The following is a description of a gene set: Cholecystitis Human Gene Set: HP_CHOLECYSTITIS The presence of inflammatory changes in the gallbladder. species: Homo sapiens, and this is the list of marker genes: F5, ATP8B1, HK1, IGHG2, TPI1, PKLR, POT1, TFE3, ABCB4, GPI, IGKC, ARSA, ALDOA, MECP2, ABCB11, NR1H4, PSAP, CALR, JAK2, PNPLA2